Given this list of marker genes Akr1c12, Cbr4, Akr1c13, Bmp2, Akr1cl, Wnt4, Akr1c21, Cacna1h, Hsd11b2, Akr1c6, Dgkq, Akr1a1, Akr1c19, Bmp5, Akr1c14, Cyp11b1, Cyp11b2, Akr1c18, Akr1b1, Rest, Cyp11a1, Dkk3, H6pd, Akr1c20, here is a description of the gene set: studied in species Mus musculus Mouse Gene Set: GOBP_TERTIARY_ALCOHOL_METABOLIC_PROCESS The chemical reactions and pathways involving tertiary alcohol.